The following is a description of a gene set: We have analyzed the developmental molecular programs of the mouse hippocampus, a cortical structure critical for learning and memory, by means of large-scale DNA microarray techniques. Of genes and expressed sequence tags examined, 1,926 showed dynamic changes during hippocampal development from embryonic day 16 to postnatal day 30. Gene-cluster analysis was used to group these genes into 16 distinct clusters with striking patterns that appear to correlate with major developmental hallmarks and cellular events. These include genes involved in neuronal proliferation, differentiation, and synapse formation. A complete list of the transcriptional changes has been compiled into a comprehensive gene profile database (http://BrainGenomics.Princeton.edu), which should prove valuable in advancing our understanding of the molecular and genetic programs underlying both the development and the functions of the mammalian brain. from publication Mody M, Cao Y, Cui Z, Tay KY, Shyong A, Shimizu E, Pham K, Schultz P, Welsh D, Tsien JZ (PMID 11438693) Mouse Gene Set: MODY_HIPPOCAMPUS_POSTNATAL Genes up-regulated in hyppocampus at late postnatal stages (clusters 11 and 15). species: Mus musculus, and this is the list of marker genes: Tpi1, Ndufb2, Cx3cl1, Apbb1, Rasgrf1, Nrgn, Sdha, Mdh1, Stxbp1, Dgkz, Eno2, Hras, Kcnma1, Cltb, Nptx1, Pfkl, Atp6v1b2, Cox8a, Aip, Syt1, Mapk3, Bdnf, Ptk2b (NCBI Gene Id 211703), Napa, Sirt3, Gria2, Grina, Fbxw7, Prdx6, Atp6v1c1, Pygm, Egr1, Vdac1, Ppp3ca, Vamp2, Gria1, Gpd1, Eef1a2, Atp2a2, Arhgef25, Ntsr2, Pkm, Atp6v1e1, Ndufs2, Ryr2, Rhob, Bin1, Kcnab1 (NCBI Gene Id 16497), Sh3gl2, Cck, Ldhb, Aldoa, Atp6ap1, Sox10, Tyro3, Gk